Given this list of marker genes LHX5, GAS2, SERPINA3, MAFG, DLK1, PIKFYVE, FAM156A, TAT, CLGN, PPP2R2B, VEGFB, ESRRG, STEAP2, EAF1, HOXC4, LDLR, SLC6A5, MYC, ADGRE5, ANKRD35, PRDX1, WNT8B, FBLN7, CD59, PHLDA3, PHF20, SLC26A6 (solute carrier family 26 member 6), P2RY14, CD151, KCNJ14, GLRX3, MRAP2, CROT, LYVE1, LRRC27, SERPINB1 (NCBI Gene Id 1992), HMGA1, PANX2, HLA-DRB1, ASAH2, CCT8, KLHL36, SLC6A9, EIF5A2, FZD8, NRG1, P2RX5, MINAR1, ACBD3, MAP3K20, TNKS, KCNG4, KCNAB2, P2RX6, NSDHL, HARS2, SPP1, FNTA, EFCAB3, ABHD8, ANXA5, CYP4F8, UFC1, ADIPOR2, ANKRD55, TRIP10, RASSF4, SLC34A1, GLRA4, GLRA1, ENTPD3, ANXA2, PMP22, FSTL1, UBLCP1, KANK4 (KN motif and ankyrin repeat domains 4), PCSK6, CHRNB4, HOXB6, GPR101 (NCBI Gene Id 83550), SLC45A3, SLC17A6, SV2C, MARCHF2, CAPN1, AR, here is a description of the gene set: Molecular approaches to understanding the functional circuitry of the nervous system promise new insights into the relationship between genes, brain and behaviour. The cellular diversity of the brain necessitates a cellular resolution approach towards understanding the functional genomics of the nervous system. We describe here an anatomically comprehensive digital atlas containing the expression patterns of approximately genes in the adult mouse brain. Data were generated using automated high-throughput procedures for in situ hybridization and data acquisition, and are publicly accessible online. Newly developed image-based informatics tools allow global genome-scale structural analysis and cross-correlation, as well as identification of regionally enriched genes. Unbiased fine-resolution analysis has identified highly specific cellular markers as well as extensive evidence of cellular heterogeneity not evident in classical neuroanatomical atlases. This highly standardized atlas provides an open, primary data resource for a wide variety of further studies concerning brain organization and function. Top 100 ranked genes most specific to medulla (myelencephalon) hindbrain region of adult mouse brain. Human Gene Set: LEIN_MEDULLA_MARKERS from publication Lein ES, Hawrylycz MJ, Ao N, Ayres M, Bensinger A, Bernard A, Boe AF, Boguski MS, Brockway KS, Byrnes EJ, Chen L, Chen L, Chen TM, Chin MC, Chong J, Crook BE, Czaplinska A, Dang CN, Datta S, Dee NR, Desaki AL, Desta T, Diep E, Dolbeare TA, Donelan MJ, Dong HW, Dougherty JG, Duncan BJ, Ebbert AJ, Eichele G, Estin LK, Faber C, Facer BA, Fields R, Fischer SR, Fliss TP, Frensley C, Gates SN, Glattfelder KJ, Halverson KR, Hart MR, Hohmann JG, Howell MP, Jeung DP, Johnson RA, Karr PT, Kawal R, Kidney JM, Knapik RH, Kuan CL, Lake JH, Laramee AR, Larsen KD, Lau C, Lemon TA, Liang AJ, Liu Y, Luong LT, Michaels J, Morgan JJ, Morgan RJ, Mortrud MT, Mosqueda NF, Ng LL, Ng R, Orta GJ, Overly CC, Pak TH, Parry SE, Pathak SD, Pearson OC, Puchalski RB, Riley ZL, Rockett HR, Rowland SA, Royall JJ, Ruiz MJ, Sarno NR, Schaffnit K, Shapovalova NV, Sivisay T, Slaughterbeck CR, Smith SC, Smith KA, Smith BI, Sodt AJ, Stewart NN, Stumpf KR, Sunkin SM, Sutram M, Tam A, Teemer CD, Thaller C, Thompson CL, Varnam LR, Visel A, Whitlock RM, Wohnoutka PE, Wolkey CK, Wong VY, Wood M, Yaylaoglu MB, Young RC, Youngstrom BL, Yuan XF, Zhang B, Zwingman TA, Jones AR (PMID 17151600) species: Mus musculus